The following is a description of a gene set: Reactome Pathway: Insertion of tail-anchored proteins into the endoplasmic reticulum membrane Tail-anchored (TA) proteins have a hydrophobic transmembrane domain (TMD) located near the C-terminus ("tail") of the protein. Depending on the nature of the TMD, TA proteins can be inserted into the endoplasmic reticulum (ER) membrane by at least 4 mechanisms: cotranslational insertion by the signal recognition particle (SRP), post-translational insertion by ASNA1 (TRC40), post-translational insertion by the SRP, and post-translational insertion by a SRP-independent mechanism (SND). Much of the information about the mammalian system of insertion by ASNA1 (TRC40) has been inferred from the Saccharomyces cerevisiae homologue Get3.<br> Prior to post-translational insertion by ASNA1, SGTA binds the transmembrane domain of the substrate TA protein immediately after translation, the SGTA:TA protein complex then binds the BAG6 complex (BAG6:GET4:UBL4A) via UBL4A, and the TA protein is transferred to ASNA1, also bound by the BAG6 complex via UBL4A. The ASNA1:TA protein complex then docks at the WRB:CAMLG (WRB:CAML) complex located in the ER membrane and the TA protein is inserted into the ER membrane by an uncharacterized mechanism that involves ATP and the transmembrane domain insertase activity of the WRB:CAML complex.<br>Misfolded TA proteins, overexpressed TA proteins, and membrane proteins mislocalized in the cytosol bind SGTA but are not efficiently transferred to ASNA1 and, instead, are retained by BAG6 which recruits RNF126 to ubiquitinate them, targeting them for degradation by the proteasome. species: Homo sapiens part of: Protein localization, and this is the list of marker genes: SEC61G, APP, ALDH3A2, GET1, CAMLG, GET3, GET4, UBL4A, UBE2J2, HMOX1, STX1A, VAPA, OTOF, SEC61B, PRNP, SGTA, BAG6, VAMP2, CYB5A, SERP1, STX5, EMD